The following is a description of a gene set: Human Gene Set: GOBP_REGULATION_OF_HEPATOCYTE_APOPTOTIC_PROCESS Any process that modulates the frequency, rate or extent of hepatocyte apoptotic process. studied in species Homo sapiens, and this is the list of marker genes: MIR675, PRKAA1, ADAR, RB1, STK4 (NCBI Gene Id 6789), PRKAA2, CFLAR, PPARA